The following is a description of a gene set: studied in species Homo sapiens Human Gene Set: REACTOME_GLUCURONIDATION Glucuronidation, and this is the list of marker genes: UGT2B7, UGT1A3, UGT2B17, UGT3A2, UGT2B15, UGT1A6, UGT1A7, SLC35D1, UGDH, UGT2B10, SLC35D2, UXS1, UGT2B11, UGT1A8, UGT1A5, UGT2A3, UGT1A10, UGT2A1, UGT2B28, UGT2A2, UGT2B4, UGT1A1, UGT3A1, UGT1A4, UGP2, ABHD10, UGT1A9